The following is a description of a gene set: Any process that activates or increases the frequency, rate, or extent of interleukin-1 production. studied in species Homo sapiens Human Gene Set: GOBP_POSITIVE_REGULATION_OF_INTERLEUKIN_1_PRODUCTION, and this is the list of marker genes: MIR206, TMEM106A, AZU1, P2RX7, CLEC7A, TNF, PANX3, RIPK2, HAVCR2, NLRP3, MALT1, TLR4, CD36, NOD2, IFI16, F2RL1, IGHD, CASP1, NLRP2, CALCA, GSDMD, EGR1, NLRC4, CCL19, IL16, IL17A, APP, HSPB1, MIR144, CARD8, STMP1, CCL3, LPL, SMAD3, HMGB1, S100A13 (NCBI Gene Id 6284), TYROBP, TMED10, GBP5, SAA1, JAK2, IFNG, CASP8, MEFV (MEFV innate immunity regulator, pyrin), WNT5A, NLRP1, AGER, PANX2, PYCARD, LILRA5, INAVA, TRIM16, ORM2, RELA, NAIP, TLR6, FZD5, ORM1, NOD1, TLR8, IL6, LILRA2, USP50, MYD88, ISL1, PANX1, AIM2, NLRP12, NLRP10, HDAC2, LGALS9, PYDC1, HK1, STAT3